The following is a description of a gene set: Binding to a glycoside in which the sugar group is galactose. studied in species Homo sapiens Human Gene Set: GOMF_GALACTOSIDE_BINDING, and this is the list of marker genes: LGALS9C, LGALS2, LGALS4, LGALS9B, LGALS9, GLB1